The following is a description of a gene set: species: Homo sapiens The chemical reactions and pathways involving tetrapyrroles, natural pigments containing four pyrrole rings joined by one-carbon units linking position 2 of one pyrrole ring to position 5 of the next. Human Gene Set: GOBP_TETRAPYRROLE_METABOLIC_PROCESS, and this is the list of marker genes: SLCO1B3, IBA57, FXN, BLVRB, ABCD4, UGT1A4, ALAD, TMEM14A, CYP1A1, COX10, BLVRA, PGRMC1, COX15, ABCB7, TMEM14EP, SLC48A1, CYP1A2, AMN, SPTA1, HMOX2, TMEM14B, MMACHC, SLC6A9, TMEM14C, SLC46A1 (solute carrier family 46 member 1), SLC25A38, ALAS1, SLC11A2, MMAB, HMBS, TSPO, SLCO2B1, MMAA, SUCLA2, SRRD, CLYBL, IREB2, CUBN, CPOX, MTRR, EIF2AK1, UROS, UROD, HPX, FLVCR1, PPOX, FECH, ABCC1, MTR, AMBP, ABCB10, TMEM14DP, RSAD1 (NCBI Gene Id 55316), UGT1A1, NFE2L1, SLCO1B1, ABCB6, MMADHC, SLC25A39, BDH2, HMOX1, ALAS2, ATP5IF1, ABCC2